The following is a description of a gene set: Selenium (Se) is a trace element essential for the normal function of the body. Selenoamino acids are defined as those amino acids where selenium has been substituted for sulphur. Selenium and sulphur share many chemical properties and so the substitution of normal amino acids with selenoamino acids has little effect on protein structure and function. Both inorganic (selenite, SeO3(2-); and selenate, SeO4(2-)) and organic (selenocysteine, Sec; and selenomethionine, SeMet) forms of selenium can be introduced in the diet where they are transformed into the intermediate selenide (Se(2-)) and then utilized for the <I>de novo</I> synthesis of Sec through a phosphorylated intermediate in a tRNA-dependent fashion. The final step of Sec formation is catalyzed by O-phosphoseryl-tRNA:selenocysteinyl-tRNA synthase (SEPSECS) that converts phosphoseryl-tRNA(Sec) to selenocysteinyl-tRNA(Sec).<br><br>All nutritional selenium is metabolised into selenide directly or through methylselenol (MeSeH). Sec liberated from selenoproteins is transformed to Se(2-) by selenocysteine lyase (SCLY). SeMet liberated from general proteins and from free SeMet sources is transformed into Se(2-) either through MeSeH by cystathionine gamma-lyase (CTH) followed by demethylation (SeMet to CH3SeH to H2Se), or through Sec by SCLY after the trans-selenation pathway (SeMet to Sec to H2Se). MeSec is hydrolysed into MeSeH by CTH. Methylseleninic acid (MeSeO2H) is reduced to methylselenol. MeSeH is demethylated to Se(2-) for further utilization for selenoprotein synthesis or oxidised to selenite (SeO3(2-)) for excretion in the form of selenosugar. Additionally, MeSeH is further methylated to dimethylselenide (Me2Se) and trimethylselenonium (Me3Se+) for excretion. part of: Metabolism of amino acids and derivatives Reactome Pathway: Selenoamino acid metabolism species: Homo sapiens, and this is the list of marker genes: RPS7, RPS29, RPL15, RPL22L1, RPL30, MARS1, RPL12, RPLP1, RPS3A, UBA52, RPS4X, HNMT, RPS14, RPL7A, RPS13, RPS23, EEFSEC, NNMT, RPL21, RPS20, RPL35A, FAU, RPL10, RPL5, QARS1, GSR, RPS12, RPS15A, RPSA (ribosomal protein SA), RPL26L1, RPL10L, PAPSS2, RPL6, RPL22, RPL24 (NCBI Gene Id 6152), RPL4, RPS3, RPL36A (NCBI Gene Id 6173), 28S rRNA, RPL11, 5.8S rRNA, AIMP2, RPS28, 18S rRNA, DARS1, RPS2, RPS19, RPS5, IARS1, RPLP2, PSTK, RPL17, RPL18A (ribosomal protein L18a), RPL36, RPS6, RPL14, RPL35, RPL13, SEPSECS, RPS16, TXNRD1, RPL28, RPL39, 5S rRNA, RPS10, RPLP0, RPS15, INMT, RPL23A, RPL36AL, RARS1, CBS, RPS24, RPS17, RPL27, RPS25, SEPHS2, RPL3L (NCBI Gene Id 6123), CTH, RPL18 (NCBI Gene Id 6141), RPS27, RPS4Y2, SARS1, RPL26, RPL39L, RPL10A, RPL23, EEF1E1, RPS9, RPL41, RPL32, RPL13A, SECISBP2, RPL29, RPL37A, RPL3, RPL7, SCLY, RPS27A, RPL27A, AHCY, GNMT, RPS21, PAPSS1, RPL19, RPS18, RPS4Y1, RPL38, RPS26, RPL8, LARS1, AIMP1, RPS8, RPL31, RPS11 (ribosomal protein S11), MAT1A, RPL9, RPS27L, KARS1, EPRS1, RPL34, RPL37